Given this list of marker genes Gpx4, Selenok, Pnpo, Alox5, Xdh, Gpx6, Txnrd2, Gpx2, Selenow, Msrb1, Cat, Cbs, Gpx1, Ptges, Fads2, Mthfr, Gpx3, Mtr, Txnrd1, Kmo, Ptgds, Gsr, here is a description of the gene set: Folic acid network studied in species Mus musculus Mouse Gene Set: WP_FOLIC_ACID_NETWORK